The following is a description of a gene set: Human Gene Set: GAVISH_3CA_METAPROGRAM_FIBROBLASTS_CAF_6 studied in species Homo sapiens In this study, an extensive analysis was conducted to define meta-programs (MPs) capturing intra-tumor heterogeneity across a spectrum of tumor types. The approach utilized non-negative matrix factorization (NMF) to analyze each cell type separately within individual tumor samples. This involved the analysis of malignant cells, macrophages, fibroblasts, endothelial cells, epithelial cells, T-cells, and B-cells. NMF was executed with varying parameter values (K=4, 5, 6, 7, 8, 9), thereby generating 39 programs for each cell type per sample. Each NMF program was summarized by the top genes based on NMF coefficients.\nRobust MPs were then delineated for each cell type using a set of stringent criteria, including recurrence within the same tumor, similarity to programs in other tumors, and non-redundancy within a tumor. Subsequently, these robust NMF programs were clustered (per cell type) based on Jaccard similarity, leading to the identification of MPs associated with each cell type.\nTo enhance the quality of the MPs, a refinement steps were undertaken, involving the removal of MPs suspected of reflecting low-quality data (with an overrepresentation of ribosomal proteins or mitochondrial-encoded genes), single-study inclusion, or similarity to miss-annotated cell types. from publication Gavish A, Tyler M, Greenwald AC, Hoefflin R, Simkin D, Tschernichovsky R, Galili Darnell N, Somech E, Barbolin C, Antman T, Kovarsky D, Barrett T, Gonzalez Castro LN, Halder D, Chanoch-Myers R, Laffy J, Mints M, Wider A, Tal R, Spitzer A, Hara T, Raitses-Gurevich M, Stossel C, Golan T, Tirosh A, Suvà ML, Puram SV, Tirosh I (PMID 37258682) Genes upregulated in subsets of cells of a given type within various tumors, and this is the list of marker genes: TIMP3, PHLDA2, CD9, FSTL3, HAS1, GPRC5A, MRGPRF, DES, CRIP2, MYADM, LRRFIP1, TGM1, PLEC, LUM, EMP3, TNFRSF11B, KRT7, MEG3, TOB1, SLC12A8, UAP1, IL18, SPON2, CRIP1, BDKRB1, ERRFI1, KLF2 (NCBI Gene Id 51713), KLF6, EZR, YWHAH, BAMBI, SERPINB2 (NCBI Gene Id 5055), EMP1, IGFBP6, SERPINE1, KRT18, MAP1B, TAGLN, CITED2, RHOB, CLIC3, JUND, KRT19, LINC01133, CD44, TPPP3, FLNB, ANXA3, TUBB2A, TM4SF1